Given this list of marker genes THEM6, OR7E14P, SERPINE2, SLC43A1, RPS6KA1, SLA, SSBP3, NMU, NPDC1, ART4, RBM15B, TRIM26, WDCP, MVB12B (multivesicular body subunit 12B), VSTM4, COQ6, TBKBP1, DPYSL2, PCK1, C1orf216, PNMA1, DCP1A, STXBP1, GPR143, TNNI3K, CCDC88C, CTDSPL, P2RY11, ATP6V1B2, PRSS23, WASL, SPRED2, EPB41L4B, CHIA, NPTX1, FUT8, KCNC3, TFR2, GLB1L2 (NCBI Gene Id 89944), POFUT2, NFX1, KPNA1, TST, ACO2, CDR2, PDGFRB, GOLM1, AP1M2, BTBD7, L1TD1, NBL1, PELP1, TOP6BL, HRAS, CXCL8, DPT, CTSH, RAB3GAP1, FLOT1, IP6K2, PQBP1, BMP3, ESRRA, PIP5K1C, XYLT1, GSAP, RAB33B, BACH2, ST8SIA3, ANK3, RDX, RIPOR2, KRT75, RPL24, TUFT1, NTRK1, TMEM131, H2BC9, AZGP1, FHOD1, GPATCH3, ZBTB32 (zinc finger and BTB domain containing 32), CLDN8, AKT1, JUN, TRPS1, LY6E, ASXL2, LSAMP, ACACA, FGGY, CNKSR1, ZBTB20, PAPSS2, IL12RB2, PLXNB2, TRPM4, NUMB, RPL12, INTS11, LPAR4, NBEA, DUSP1, HLA-DOB, MEST, TWIST1, DMRT1, IER3, STX18, DIXDC1, MDM1, RCAN1, LAIR1, SLC2A9, MAGEB4, MID1IP1, SMAD7, GPR63, DRICH1, APPL1, TRPM3, ACADSB, MASP2, TMEM35A, URGCP, ZNF556, PTEN, DNAJC6, PTCD1, CYFIP2, ELOVL6, C8A, ARHGEF2, NRF1, ANKMY1, FBXO31, TGIF1, PMPCA, GPRC5C, ASRGL1, SNX24 (sorting nexin 24), PAM, TMEM184B, PNO1, GSTT4, TMPRSS11E, PEA15, PTPN3, TRAF3, ATP8A2, SRD5A3, EXOSC7, EPHX1, CNGA1, COL6A3, C2CD2, CCDC40, GGNBP2, KLHDC10, SHTN1, OLFML1 (NCBI Gene Id 283298), ZFP36L1, PIN1, TRIP6, RPAP1, MAPK12, NR4A3, BBS9, B3GALNT1, NCLN, MPZ, TBCCD1, NKAPD1, UCHL1, BICD2, SCN11A, REG1B, BCR, TUT1, ELOVL1 (ELOVL fatty acid elongase 1), DBN1, ANXA5, MAGEH1, NOD1, OTUB2 (NCBI Gene Id 78990), PSME4, GPR25, CAMTA1, LY6G6C, H2BC11, PLSCR1, TBX21, RIOX2, CDC25B, TLCD3A, CD226, LEPROT, KIF21B, ZEB2, here is a description of the gene set: studied in species Homo sapiens Genes up-regulated in comparison of stimulated CD4 Th1 cells at 12 h versus stimulated CD4 Th2 cells at 12 h. Human Gene Set: GSE22886_TH1_VS_TH2_12H_ACT_UP from publication Abbas AR, Baldwin D, Ma Y, Ouyang W, Gurney A, Martin F, Fong S, van Lookeren Campagne M, Godowski P, Williams PM, Chan AC, Clark HF (PMID 15789058) Immune cell-specific expression is one indication of the importance of a gene's role in the immune response. In order to identify such patterns, we set out to broadly profile gene expression in a variety of immune cells.